Given this list of marker genes USP5, EGLN1, RAB26, PRKN, CUL3, CBLB (NCBI Gene Id 868), here is a description of the gene set: Human Gene Set: GOBP_REGULATION_PROTEIN_CATABOLIC_PROCESS_AT_SYNAPSE studied in species Homo sapiens Any process that modulates the frequency, rate or extent of the chemical reactions and pathways resulting in the breakdown of a protein at the synapse.